The following is a description of a gene set: species: Mus musculus Mouse Gene Set: GOBP_REGULATION_OF_GRANULOCYTE_CHEMOTAXIS Any process that modulates the rate, frequency or extent of granulocyte chemotaxis. Granulocyte chemotaxis is the movement of a granulocyte in response to an external stimulus., and this is the list of marker genes: C1qbp (NCBI Gene Id 28127), Trpv4, Ednra, Cd74, Thbs4, Cxcl17, Cx3cl1, Camk1d, Il34, Slamf1, Ccl2, Mapk1, Il4, Sell, Il1b, Cmklr1, Nod2, Ptprj, Ccl21d, Mpp1, Edn1, Ccl21f (NCBI Gene Id 100504346), Xcl1, C5ar2, Csf1, Mstn, Lbp, Ccl21e, Tnfaip6, Ptk2, Ccl5, Ccr7, Il23a (NCBI Gene Id 83430), Ppbp, Rac2, Ripor2, Jam3, Dpp4, Ccl19-ps3, Mcu, C3ar1, Tirap, Ccl19-ps5, Tnfsf18, Csf1r, Nckap1l, Trem1, Ccl19, Ccl19-ps6, Akirin1, Slit2, Cxcr2, Ccl19-ps4, Mapk3, Ccl21a, Rarres2, Ccl19-ps1, Rac1, Mdk, Dapk2, Mospd2, Dysf, Bst1 (NCBI Gene Id 269647), Thbs1, S100a14, Dnm1l, C5ar1, Perp, Ccl21b